Given this list of marker genes C4BPB (complement component 4 binding protein beta), HPX, FCER2, CR2, C1S, IGHA2, CFI, FCMR, IGHA1, PTPRC, LTA, SERPING1, EXO1, CLU, IGHD, C1RL, FCGR2B, IGHG3, C4B, TNF, C6, SUSD4, CD46, C1QA, C8B, C1QC, MASP2, ZP3, IGHG2, C4BPA, CR1L, TREM2, BCL3, CR1, IGHG4, MBL2, C1QBP, CD81, C8A, C3, IGHE, C1QB, C9, C4A, C7, C1R, CD55, PTPN6, C5, IGHG1, FOXJ1, C8G, C2, here is a description of the gene set: Human Gene Set: GOBP_HUMORAL_IMMUNE_RESPONSE_MEDIATED_BY_CIRCULATING_IMMUNOGLOBULIN species: Homo sapiens An immune response dependent upon secreted immunoglobulin. An example of this process is found in Mus musculus.